Given this list of marker genes Cyp1b1, Cyp3a57, Cyp3a59, Cyp3a16, Cyp3a44, Cyp3a41b, Cyp3a41a, Cyp3a13, Cyp3a11, Cyp3a25, Cyp46a1, here is a description of the gene set: species: Mus musculus Catalysis of the reaction: O2 + reduced + testosterone = 6beta,17beta-dihydroxyandrost-4-en-3-one + H+ + H2O + oxidized. Mouse Gene Set: GOMF_TESTOSTERONE_6_BETA_HYDROXYLASE_ACTIVITY